Given this list of marker genes TAF4, DCTN1, CRX, GRN, CRB1, RPGRIP1, TULP1, IQSEC2, MAPT (NCBI Gene Id 8152), CHMP2B, ATP10A, LCA5, RPE65, NMNAT1, IMPDH1, RFX7, CEP290, SHANK3, DEAF1, RAI1, GDF6, FLII, PRKAR1B, PCYT1A, PSEN1, RD3, AIPL1, IFT140, TMEM106B, MYT1L, USP45, KCNJ13, TREM2, TUBB4B, GUCY2D, RNU4-2, LRAT, SPATA7, VCP, UBE3A, IQCB1, RDH12, SQSTM1 (NCBI Gene Id 94002), PRNP, CRLS1, SNRPN, here is a description of the gene set: species: Homo sapiens Human Gene Set: HP_SENSORY_SEEKING Unusual interest in sensory aspects of the environment. Sensory seeking